Given this list of marker genes HOXD11, VSX2, SALL4, PITX1, GSC, HOXA13, NPAS1, DMC1, CYP26A1, PITX2, EPCAM, NTF4, IGF2, TFAP2E, BARX1, SCNN1B, DRGX, MAFA, NEUROG1, IRS3P, CDX1, DRD4, SIX1, NEUROG3, IGFBPL1, DLX4 (distal-less homeobox 4), POU2F3, TCFL5, HOXC4, FGF20, GFI1, GFRA3, MIXL1, KRT7, TDH, THEM7P, KCP, AEBP1, HOXC5, PRRX2, LHX5, GRIN3B, COL8A2, IRX6, HOXB4, OLIG3, IGF2BP3 (insulin like growth factor 2 mRNA binding protein 3), PROM2 (NCBI Gene Id 200480), DMGDH, PKP1, WNT10B, DMRT1, FGF8 (NCBI Gene Id 2253), RBMXL2, SPINT1, HMX2, LBX1, HOXA10, DLX3, RAX, DLK1, PRDM13, TDRD6, CALCR, SCARF2, TBX21, GPR50, IGF2BP1, FGF17, TPM2, CRB3, BARHL2, PPM1N, FGF4, CHAT, INSM2, KCNK15, WT1, ALX1, WNT7B, LOXL1, TBX1, SIM2, OTOP1 (NCBI Gene Id 133060), SFRP5, DMRTA1, PHOX2A, HMX3, TFAP2C, HELT, CBLC, BNC1, KRT18, CELSR1, TMEM54, TMEM30B, CDX2, NAGS, IRX2 (NCBI Gene Id 93965), PTF1A, TLX1, HOXC12, BMP8B, PLBD1, MNX1, KRT19, FEV, HOXD10, KCNE5, LBX2, PRDM6, UNCX, SPAG6, IL12RB2, HAND2, FOXB1, HOXB5, GNAS, PRSS50, HOXC13, WNT3A, ERFE, LHX1, ATP2A3, SIX6, CLDN7, NKX2-5, ADAMTS14, ALX3 (NCBI Gene Id 93575), GATA5 (NCBI Gene Id 140628), FGF3, NKX2-4, LTBP2, GBX1, HOXC11, WNT3, RSPO4, OVOL1 (NCBI Gene Id 5017), DBX1, PDX1, CLDN3, DMBX1, GRB10, HES2, EMILIN3, SLC47A1 (NCBI Gene Id 55244), VAX2, RHCG, FOXL1 (forkhead box L1), POU4F3, UTF1, NOTCH3, NKX2-1, GATA3, HOXA11, FOXB2, MESP1, LARGE2, FOXA2, TMEM171, SPAG16, WNT2B, HOXB6, B4GALNT2, LHX3, SLC47A2, MMP2, ANKRD53, HOXD12, ALX4, ESPN, HOXA4, FOXD4, HOXC8, ECEL1, GLP1R, GAL, GSX2, SLC5A5, INSRR, FOXE3, SLC44A3, CHMP4C, SLC18A2, LMX1B, HOXD1, GBX2, POU4F2, SLC18A3, PRDM14, GNMT (glycine N-methyltransferase), PAX7, ESX1, IRF6, FOXC2, SIM1, LHX8, FOXD2, HOXB9, KDF1 (keratinocyte differentiation factor 1), ALDH1A3, IRX4, B3GNT3, FOXE1, PLEKHG6, FOXN4, DIO3, PAX1, NKX6-1, TRPV4, THBS4, NPY, DHH, ZNRF4, DMRT3, BHLHE23, MFSD6L (NCBI Gene Id 162387), BARHL1 (NCBI Gene Id 56751), AMN, LMX1A, HNF1B, CRLF1, CYP4F22, PCSK9, CYP24A1, MYOD1, FGFR4, EVX1, TNXB, BCL3, PYY, TNFAIP2, MARCKSL1, SLC30A2 (NCBI Gene Id 84555), FAM89A, HOXB7, OTP, HAND1, GJA3, HMX1, NKX3-2, COL13A1, CLDN4, SIX2, FOXD3, DRAXIN, PRR5, CALB2, FFAR4, TLX3, AQP5, LGR6, TBXT, SLC6A2, CHRNA3, HOXD8, PAX2, TLX2, NCMAP, CDCP1, HOXA5, HMGA2, HOXD9, GDF7, GATA4 (GATA binding protein 4), HOXD13, TP73, IKZF3, REM1, HES3, ONECUT3, WDR86, here is a description of the gene set: studied in species Mus musculus DNA methylation is essential for normal development and has been implicated in many pathologies including cancer. Our knowledge about the genome-wide distribution of DNA methylation, how it changes during cellular differentiation and how it relates to histone methylation and other chromatin modifications in mammals remains limited. Here we report the generation and analysis of genome-scale DNA methylation profiles at nucleotide resolution in mammalian cells. Using high-throughput reduced representation bisulphite sequencing and single-molecule-based sequencing, we generated DNA methylation maps covering most CpG islands, and a representative sampling of conserved non-coding elements, transposons and other genomic features, for mouse embryonic stem cells, embryonic-stem-cell-derived and primary neural cells, and eight other primary tissues. Several key findings emerge from the data. First, DNA methylation patterns are better correlated with histone methylation patterns than with the underlying genome sequence context. Second, methylation of CpGs are dynamic epigenetic marks that undergo extensive changes during cellular differentiation, particularly in regulatory regions outside of core promoters. Third, analysis of embryonic-stem-cell-derived and primary cells reveals that 'weak' CpG islands associated with a specific set of developmentally regulated genes undergo aberrant hypermethylation during extended proliferation in vitro, in a pattern reminiscent of that reported in some primary tumours. More generally, the results establish reduced representation bisulphite sequencing as a powerful technology for epigenetic profiling of cell populations relevant to developmental biology, cancer and regenerative medicine. from publication Meissner A, Mikkelsen TS, Gu H, Wernig M, Hanna J, Sivachenko A, Zhang X, Bernstein BE, Nusbaum C, Jaffe DB, Gnirke A, Jaenisch R, Lander ES (PMID 18600261) Human Gene Set: MEISSNER_BRAIN_HCP_WITH_H3K27ME3 Genes with high-CpG-density promoters (HCP) bearing the H3K27 tri-methylation (H3K27me3) mark in brain.